The following is a description of a gene set: species: Homo sapiens The process whose specific outcome is the progression of the blood vessels of the heart over time, from its formation to the mature structure. Human Gene Set: GOBP_CORONARY_VASCULATURE_DEVELOPMENT, and this is the list of marker genes: TAB1, FGF2, CNTRL, ZBTB14, MIR145, APLNR, APELA, TGFBR1, TBX1, AP2B1, MIR1-1, MEGF8, MYOCD, SGCD, SEC24B, NRP1, PRICKLE1, SUFU, ADAMTS6, DYNC2H1, HEY2, MYH10, PRDM1, VEGFA, DCTN5, SRF (NCBI Gene Id 6722), LRP2, TBX5, NDST1, PDGFRB, TGFBR3, GATA6, PTK7, VEGFB, SMAD6, APLN, KCNJ8, HAND2, BMP4, ABCC9, SPRED1, MMP21, PLXND1, NOTCH1, GPER1, ARID2, GPC3, MESP1, SNX17